Given this list of marker genes SQSTM1, UIMC1, RPS29P12, OR2V2, MAPK9, OR2V1, SNCB, HK3, SLIT3-AS1, NKX2-5, INSYN2B, ARL2BPP6, TRIM41 (NCBI Gene Id 90933), KCNIP1-OT1, RPL26L1-AS1, MIR4634, ENSG00000253163, RPL26L1, KLF3P1, SNORD95, RNU1-39P, PDLIM7, KCNIP1, MIR8089, TLX3, DUSP1, RNU1-17P, RPL10P8, SCGB3A1, LINC01485, SUMO2P6, BRCC3P1, SPDL1 (NCBI Gene Id 54908), ENSG00000285914, RNU6-500P, RN7SL646P, LINC00847, AACSP1, FBXW11, PFN3, HRH2, RNF130, KIAA1191, OR2AI1P, HIGD2A, ZNF346-IT1, SUDS3P1, CANX, MGAT4B, ARPP19P1, ZNF454-DT, FOXI1, ENSG00000249186, EIF4E1B, MIR3912, TRIM52-AS1, DRD1 (dopamine receptor D1), GRK6, DOK3, GABRP, ENSG00000253295, TRIM52, RNU6-226P, FAM193B-DT, RGS14, ADAMTS2 (ADAM metallopeptidase with thrombospondin type 1 motif 2), ENSG00000307151, ENSG00000287003, RAB24, OR2Y1, PRELID1, OR1X5P, MIR1271, RN7SKP70, HNRNPH1, STK10, LINC01942, TRIM7-AS2, EFCAB9, UNC5A, C5orf47, CLK4, ENSG00000251545, TSPAN17, FLT4, ZNF354B, FGFR4, LINC01366, COL23A1, ZNF346, KRT18P41, ARL10, OR1X1P (olfactory receptor family 1 subfamily X member 1 pseudogene), SNORD96A, HEIH, RPSAP71, RPL21P60, CDHR2, RACK1, PDLIM7-AS1, RNU6-525P (RNA, U6 small nuclear 525, pseudogene), ATP6V0E1, KCNIP1-AS1, LINC01187, ENSG00000250274, SMIM23, SLC34A1, PROP1, LINC01962, DOCK2, BNIP1, CBY3, RN7SL623P, CLTB, LINC01944, MIR5003, B4GALT7, ENSG00000248469, HMGB3P22, SH3PXD2B, RPL23AP45, UBTD2, RNF44 (NCBI Gene Id 260352), CEP192P1, ERGIC1, PRDX2P3, TMEM69P2, DBN1, ZNF454, FAF2, CPEB4, RN7SL339P, ENSG00000308026, GMCL2, SFXN1, USP12P1, SNORA74B, ENSG00000253736, HIGD1AP3, BTNL9, LINC02222, NSD1, LINC01574 (long intergenic non-protein coding RNA 1574), MIR340, MXD3, CPLX2 (NCBI Gene Id 84242), LTC4S, ENSG00000307523 (NCBI Gene Id 124901154), RUFY1-AS1, OR4F3 (olfactory receptor family 4 subfamily F member 3), C5orf58, NHP2, ENSG00000248367, PRR7-AS1, MIR8056, RNU6-705P, MRNIP-DT, ZFP2, MIR1229, ENSG00000253348, ENSG00000309157, ZNF879, LINC01484, MAML1, BOD1 (NCBI Gene Id 91272), ENSG00000287814, PRR7, FAM153CP, FAM153A, GAPDHP71, LINC01411, SIMC1, CDC42P5, FAM193B, TBC1D9B, MIR585, RNU6-1036P, LMAN2, RPL7AP33, ZFP62, ZNF354A, FOXO1B, SPATA31J1 (SPATA31 subfamily J member 1), RUFY1, SIMC1P1, NPM1, SLIT3, TRIM7-AS1, RMND5B, PRMT1P1, MIR4638, ENSG00000288912, WBP1LP4 (NCBI Gene Id 106480779), LINC01951, PHYKPL, MSANTD5, TMED9, RN7SL684P, RNA5SP200, LCP2, THOC3, THOC3-AS1, PIGFP1, MRNIP, F12, SEPTIN14P5, MIR4281, SNORA70J, ENSG00000305594, GFPT2, RANBP17, NSG2, CREBRF, FGF18, STC2, HNRNPAB, GPRIN1, N4BP3, LINC01863, TRIM7, CICP15, MSX2, NEURL1B, KCNMB1, NIFKP2, RN7SKP148, LINC02995, RNU6-477P, RN7SKP150, BTNL8, GRM6, CNOT6, RASGEF1C, ZNF354C, NOP16, MGAT1, RPL12P22, ENSG00000212529, ENSG00000294604, MIR378E, DDX41, BTNL3, RPS15AP18, here is a description of the gene set: Human Gene Set: chr5q35 studied in species Homo sapiens